The following is a description of a gene set: Human Gene Set: KEGG_MEDICUS_ENV_FACTOR_ZN_TO_ANTEROGRADE_AXONAL_TRANSPORT Zn to anterograde axonal transport. Pathway ID: N01403. Pathway type: Env factor. Pathway class: nt06460 Alzheimer disease. Pathway Definition from KEGG: Zn2+ -> GSK3B -> MAPT -| (TUBA+TUBB) species: Homo sapiens, and this is the list of marker genes: TUBA1A, TUBB1, MAPT, TUBB3, TUBA1C, TUBB8, TUBB2B, TUBA3E, GSK3B, TUBB, TUBB2A, TUBA3D, TUBA8, TUBB6, TUBB4B (NCBI Gene Id 10383), TUBA3C, TUBA1B, TUBA4A, TUBB4A